The following is a description of a gene set: Genes down-regulated in neutrophils from MIR223 bone marrow versus the wildtype cells. This array analysis is to study the regulation of target messages’ expression in in vitro cultured murine neutrophils versus miR-223 null neutrophils. Culture media was SILAC-IMDM for MS analysis. studied in species Homo sapiens from publication Baek D, Villén J, Shin C, Camargo FD, Gygi SP, Bartel DP (PMID 18668037) Human Gene Set: GSE11973_MIR223_KOVS_WT_BONE_MARROW_NEUTROPHIL_DN, and this is the list of marker genes: CPXCR1, PLA2G4F, LAPTM4B, TIMM17A, PIK3AP1, UTP18, FXR2, XPOT, CCT8, DDA1, NFYA, PTMA, PPP3R1, SELENOF, TANGO6, ALPK1, IL5, PLAU, TNFRSF25, TLCD5, RASGEF1B, ACTR3B, PRPS1, RUVBL1, TMEM209, SLC25A33, DQX1 (DEAQ-box RNA dependent ATPase 1), LY6K, PHLPP1, UQCRQ, GUCY1B1 (NCBI Gene Id 2983), GIMAP8, GIMAP7, OTUD4, AIRN, UTP6, LILRB4, STAT3, DBNL, DGKH, GORASP2, MRPL21, ADAP1, IPO5, TRAP1, PJA1 (praja ring finger ubiquitin ligase 1), N6AMT1, ADPRS, PPP5C, EIF2B3 (eukaryotic translation initiation factor 2B subunit gamma), YARS2, THG1L, FAM161B, PTAR1, PSMD7, EIF1AX, ZBTB48, PTGES3, PFDN1, GMDS, ECE2, BMS1, AATF, MRPL54, CUEDC1, CCDC25, SIAH2, RELA, FTSJ1, HSPA4L, GK5, SAMD4A, WDR82, RPL22, TFIP11, PSMB9, NUDT4, NFKBIB, SURF6, PML, LARP1, WDR70, NUP43, MCRS1, CD5, SBF2 (NCBI Gene Id 81846), RPN1, ZDHHC13, RASGRP1, IMPDH1, APRT, RPL38, CYP1A1, CCDC43, RHBDF2, SERBP1, EZH2, TAF1D, CCNJ, ADARB1, MINDY3, HNRNPU, MCRIP2, ZDHHC21, RRP15, MOCS3, PICALM, TBC1D30, ALG3, RAPGEF6, TRMT10A, GRPEL1, SMN1, SHQ1, UNK, BID, BCAT2, NUP54, FKBP2, DONSON, ITGAX, CRABP2, RND1, NUDT16L1, BEX1, ITGAV, PEX12, GRIPAP1, NOL10, RIGI, DYNLL2, EMC8, SGF29, G3BP1, TBRG4, ETFB, LMAN1, RAB3IP, RBMX2, SDHAF3, B4GALT5, ECD, KIT, CMTR2 (cap methyltransferase 2), PDZD4, MRPL30, CYCS, CD48, PPID, MRPL37, PPA2, RNF187, TNIP3, CACNG3, CTSC, NDRG1, SNRPD1, GMPPB, DOCK4, COPS8, MRPS18A, RPS25, EMC6, URM1, PTPN6, TMTC4, PARL, TSEN2, PTPN1, ANKRD49, FAM124B, IMPDH2, OCIAD2, SMAD5, TNFRSF4, COQ2, LYN